The following is a description of a gene set: The process in which a relatively unspecialized cell acquires the specialized features of a retinal cone cell. studied in species Mus musculus Mouse Gene Set: GOBP_RETINAL_CONE_CELL_DIFFERENTIATION, and this is the list of marker genes: Mir124a-1, Thy1, Gnat1, Pde6c, Mir124a-2, Notch1, Dio3, Mir183, Rp1, Thrb, Crb2, Bbs10, Hcn1, Rorb, Cnga3, Mir96, Mir182, Ahi1, Cabp4, Ush1c, Casz1, Gnat2